Given this list of marker genes GIMAP4, TM9SF2, TRMT6, IRX3, WDR45B, MYLK4, RAB38, HSPE1, EPB41L2, LBX1, GATA1, REXO2, NMB, BCL2A1, FMNL2, GADD45G, GMPPB, NUDT12, PLPP1, WDFY1, MYRIP, TSR1, SCD, RGS6, TMCC3, FCGR3A, METAP1D, NTN4, PTPRC, SLC2A12, CLCA4, ITPR1, SNX24, ESF1, PARS2, GPR183, LYAR, ICOSLG, IQCE, IFI30, ATP10D, C8orf76, EGR2, DIS3L2, HMGA2, MDFI, TMCC2, VAV3, ATF5, BCAP29, TPD52 (NCBI Gene Id 7163), ASB4, BTBD19, EXOSC9, RGS14, TAF4B, BAG2, FSCN1, ZNF329, CIITA, NSUN4, TRIM10, MANF, DPYSL5, ZNF281, CLEC2L, HOXB5, HMGCR, WNT11, SLC19A1, OSGIN2, TIMM10, NOL8, URI1, DCC, TMEM50B, ZSWIM2, KCNE4, DUS3L, BEND3 (BEN domain containing 3), SEMA7A, TTC23L (NCBI Gene Id 153657), CD5, MMP12, STX11, CFP, LY86, IL7R, GSTK1, INAFM1, C5AR1, ARFIP2, NAA16, PLEKHG2 (pleckstrin homology and RhoGEF domain containing G2), THEMIS2, ANGPTL3, MMP20, PLA2G6, EPOP, VPS13D, CCDC134 (coiled-coil domain containing 134), KAZALD1, ALDOC, PPARGC1B, NEMF, RBM28, CIB1, DHX33 (NCBI Gene Id 56919), PHTF1, TMED5, ITGA10, AEBP2, LAP3, HPS4, RGR, CTSS, CAD, NAF1, HOMER3, SLC5A4, EMID1, DENND4A, VMP1, RBPJ, HLA-DRB1, TLR7, HMGN3, LPXN, TNFRSF13C, COPG2IT1, ALPG, TCF20, GPM6A, HIGD1B, DKK4, DCTN4, BEND4, INPP5D, DANCR, DNAJC1, RPN1, MTF1 (NCBI Gene Id 4520), MRPS7, ELAPOR1, ARL14EP, TBC1D14, CCDC62, TLE3, LTV1, CALR, PRMT8, CHST11, IDUA, HIVEP3, PRMT6, CD83 (NCBI Gene Id 9308), SELENOS, NDUFAF4 (NADH:ubiquinone oxidoreductase complex assembly factor 4), MYPN, MYO10, CRX, CFAP43, NAB2, BRD2, DHX37, STK10, SKIL, RRBP1 (NCBI Gene Id 6238), GUK1, VSIG4, ZNF619, TMEM91, DPH6, PUS7L, DNAJC3, NDRG1, GIMAP5, CNBP, EIF4G3, MYO19, SLC12A3, CLPTM1L, P4HTM, CKLF, RPTOR, TOX, LIFR, GALNT6, PUM3, PIK3AP1, SYNGR2, FBXL2, BTG3, SSR4, C4orf17, NEGR1, METTL1, IMPACT, FUT9, SNX10, here is a description of the gene set: Type I and type II interferons (IFNs) bind to different cell surface receptors but activate overlapping signal transduction pathways. We examined the effects of a type I IFN (IFN-acon1) and a type II iFN (IFN-g1b) on gene experession in A549 cells and demonstrate that there is a common set of genes modulated by both IFNs as well as a set of gene specifically regulated by each, reflecting the activation of different signaling pathways. In particualr, IFN-g induced many more genes of the signaling pathways, apoptosis, and cytokine interactions than did IFN-a. Even with genes induced by both IFNs there were distinctive quantitativive differences in expression. IFN-g1b plays a major role in the induction and regulation of the complement pathway. Previous work has shown a synergistic antivral and antiproliferative effect of type I and type II IFNs in cell culture and in the treament of tumors in mice. We demonstrate that a majority of genes showed and additive effect of IFN-acon1 and IFN-g1b, but a subset of gene is synergistically induced; these incluce ISG10, MX2, OAS2, and other genes known to be involved in the antiviral response, TRAIL (TNFSF10) and caspases involved in apoptosis and chemokine genes RANTES, CXCL10, and CXCL11. Greater than additive transcription of some of these genes in the presence of both IFNs was confirmed by real-time kinetic RT-PCR. Elevated induction of many of these genes may be sufficient to explain the synergistic antiviral and antitumor effects of this combination of IFNS in vivo. Genes up-regulated in epithelial cells (24h): interferon alpha versus interferon alpha and IFNG. Human Gene Set: GSE5542_IFNA_VS_IFNA_AND_IFNG_TREATED_EPITHELIAL_CELLS_24H_UP from publication Sanda C, Weitzel P, Tsukahara T, Schaley J, Edenberg HJ, Stephens MA, McClintick JN, Blatt LM, Li L, Brodsky L, Taylor MW (PMID 16800785) species: Homo sapiens